Given this list of marker genes SPTB, RSF1, FOXS1, TCEA2, KANSL1L, UBE2H, STC2, UBE4B (NCBI Gene Id 10277), PFN1, EDN2, KCNS3, C1QL1, CD83, MIR17HG, VEZF1, SEC14L2 (NCBI Gene Id 85372), RALGDS, CXCL11, TAL1, ERN1, TIFA, SOBP, BMP2K, P2RY10, TNF, GEN1 (NCBI Gene Id 348654), CBX2, ZBTB11, LIG1, BFSP1, BIRC3, CREB1, LTA, SOX10, ADGRB2, TRAF4, ETV6, KRTAP13-1 (NCBI Gene Id 337881), GADD45B, CXCL2, UBD, BDNF, IRF1, CALCOCO1, GABRB1, SMC6, MMP9, SHOX2, CHD4, NR2F2, CXCL9, NTN1, GRIN2D, APPL1, FGF1, BCL3, MAP3K8, DAP3, MAP4K2, CCL5, ORAI1, ATP1B1, FGF17, ITGB4, MIDEAS, TNIP1, HSD3B7, GPHN, YY1AP1, COL16A1, S1PR2, HSD11B2, WRAP53, KCNN3, SLC44A1, KLK9, RIN2, DDR1, CYB5A, ZNF821, WNT10B, TSLP, PAN2, TAFAZZIN, TNFSF15, IFNB1, SDC4 (NCBI Gene Id 6385), ATOH1, CXCL6, CDK6, DCLK1, IL1RAPL1, EGF, ANKFN1, HIVEP1, ASCL3, IL4I1, SUN2, ZSCAN29, HOXA11, KCNH3, FAM117A (NCBI Gene Id 81558), SLC6A12, NOL4, ZBTB9, GGNBP2, BCKDK, ARHGAP8, BMF, CHD6, LINC01138, AAMDC, TRIM47, LRCH1 (leucine rich repeats and calponin homology domain containing 1), SLC11A2, GNB1, HSP90B1, IER5, MADCAM1, TLX1, NFAT5, HCFC1, CXCL10, COL11A2, TJAP1, GNAO1, BCL6B, NOD2, ALG6, WNT10A, ZNF232, ASH1L, UBE2D3, RBM14, HCST (hematopoietic cell signal transducer), ARPC2, VCAM1, IL27RA, ZSWIM9, RELB, IGDCC3, TRIB2, FBXL12, CCDC107, SH2B3, NFKB2, MOB3C, CXCL5, ZNF384, RAP2C, SP6, EHF, KY, SMOC1, PNKD, IL1A, MAML2, ICAM1, UACA, CCN2, CXCL16, NUFIP2, INO80D, GDPD5, ABHD8, EBI3, NFKBID, JAK3, SLC12A2, IL2RA, G3BP1 (NCBI Gene Id 10146), BNC2, TNFSF18, STON2, PCBP4, CTAGE4, NLK, ZBTB5, RBMS1, RRAS, SOX5 (NCBI Gene Id 6660), RIMS2, OPCML, TP63, STAT6, GREM1, PARP8 (NCBI Gene Id 79668), ZFP36L2, VSX2, PCSK2, SALL1, GPBP1 (GC-rich promoter binding protein 1), ACTN3, CD70, PTMS, SMPD3, MED1, MSX1, SLAMF8, CD40, FOXJ2, EIF5A, FUT7, FTHL17, IL13, NIBAN1, GATA4, XKR8, TP53, CYLD, GRK5, ENO3, PLAU, JARID2, UBE2I, RPS6KA4, CDC14A, FLRT1 (fibronectin leucine rich transmembrane protein 1), ACAN, LIX1L, ARHGAP44, TASL, AP1S2, MSC, ACTN1 (actinin alpha 1), SAMSN1, CPD, CFAP69, LAMA1, MSN, PRX, LTB, AGPAT1, ZMYND15, NFKBIB, AZIN1, HOXB9, CLCN1, TSPEAR, IL1RN, KCNT2 (NCBI Gene Id 343450), GNG4, CXCR5, MAG (myelin associated glycoprotein), RND1, SESN2, TUBGCP4, PRDM12, IL27, TNFRSF9, IL23A, TNFRSF1B, ARHGAP5, SIN3A, NIPBL, here is a description of the gene set: studied in species Homo sapiens Genes having at least one occurrence of the motif GGGAMTTYCC in the regions spanning 4 kb centered on their transcription starting sites. This matches the NFKB, RELA transcription factor binding site V$NFKAPPAB_01 (v7.4 TRANSFAC). Human Gene Set: NFKAPPAB_01